The following is a description of a gene set: Abnormally increased hair growth over much of the entire body. studied in species Homo sapiens Human Gene Set: HP_GENERALIZED_HIRSUTISM Generalized hirsutism, and this is the list of marker genes: HDAC8, HSPG2, KDSR (3-ketodihydrosphingosine reductase), NPHP1, MKKS, UBE4B, BBS2, RAB3GAP2, TWIST1, RERE, CFAP418, BMP1, SPEN, PDPN, CASZ1, PPARG, ELMO2, GJB4, SLC25A24, TWIST2, AIP, KCNAB2, IFT27, NIPBL (NCBI Gene Id 25836), SMC3, MBD5, PEPD, PRKG2, RAB18, ARX, RAB3GAP1, ARL6, LZTFL1, AKT1, LMNA, IFT74, ABCA5, GJB3, BBS1, BBS10, KCNJ8, GJA1, BBS4, IDUA, SDCCAG8, BBS5, CEP19, LMNB2, IFT172, KMT2A, PRDM16, UBE2A, TAF6, TTC8, BBS7, INSR, SKI, ABCC9, SCAPER, BBIP1, TRIM32, CTSC, CYP19A1, MMP23B, LUZP1, SUCLA2, BBS12, MAPK1, GPR101, RAD21, BRD4, NFIX, TUBB, SMC1A, MKS1 (NCBI Gene Id 54903), BBS9, MAPRE2, GABRD, TBC1D20 (NCBI Gene Id 170488), IRF6, SLC25A12, WDPCP, GNE, BSCL2, NOTCH2, PRKCZ, CEP290, SCLT1, SMO